The following is a description of a gene set: studied in species Homo sapiens Neighborhood of PRDX2 peroxiredoxin 2 in the GNF2 expression compendium Neighborhood of PRDX2 Human Gene Set: GNF2_PRDX2, and this is the list of marker genes: CA2, TFRC, HDGF, RHAG, ANK1, GCLM, AMMECR1, BLVRB, CA1, GLRX5, SPTB, AHSP, ADD2, XK, ALAD, KLF1, UBAC1, UROD, HEBP1 (NCBI Gene Id 50865), KEL, HBQ1 (NCBI Gene Id 3049), MINPP1, GYPC, PPOX, DCAF11, HMBS, TAL1, PRDX2, GATA1, CTSE, HBD